The following is a description of a gene set: species: Homo sapiens The chemical reactions and pathways involving glutamine, 2-amino-4-carbamoylbutanoic acid. Human Gene Set: GOBP_GLUTAMINE_METABOLIC_PROCESS, and this is the list of marker genes: CAD, BLOC1S6, ASL, GLUL, GLYATL1 (glycine-N-acyltransferase like 1), GLUD1 (NCBI Gene Id 2746), NIT2, GLS (glutaminase), GLS2, ARHGAP11B, SIRT4, UCP2, NR1H4, GLYATL1B, LGSN, PHGDH, ADSS1, PFAS, CPS1, MECP2